The following is a description of a gene set: studied in species Mus musculus Cytokines mediate cell-cell communication in the immune system and represent important therapeutic targets. A myriad of studies have highlighted their central role in immune function, yet we lack a global view of the cellular responses of each immune cell type to each cytokine. To address this gap, the authors created the Immune Dictionary, a compendium of single-cell transcriptomic profiles of more than 17 immune cell types in response to each of 86 cytokines (>1,400 cytokine-cell type combinations) in mouse lymph nodes in vivo. A cytokine-centric view of the dictionary revealed that most cytokines induce highly cell-type-specific responses. For example, the inflammatory cytokine interleukin-1β induces distinct gene programmes in almost every cell type. A cell-type-centric view of the dictionary identified more than 66 cytokine-driven cellular polarization states across immune cell types, including previously uncharacterized states such as an interleukin-18-induced polyfunctional natural killer cell state. Mouse Gene Set: CUI_B_CELL_IL33_RESPONSE_UP Genes positively differentially expressed in cell type: B cell upon treatment with cytokine: IL-33 in mouse lymph nodes in vivo. from publication Cui A, Huang T, Li S, Ma A, Pérez JL, Sander C, Keskin DB, Wu CJ, Fraenkel E, Hacohen N (PMID 38057668), and this is the list of marker genes: Ifi209, Ly6a, Ifi213, Ifi27l2a, Slfn2, Stat1 (NCBI Gene Id 98183), Xaf1, Rnf213, Ifi47, Pml, Phf11b, Ifit3 (NCBI Gene Id 433243), Sp110, Pkib (protein kinase inhibitor beta, cAMP dependent, testis specific), Irf7, Rtp4, Parp14, Serpina3g, Ms4a4c, Trim30a, Bst2, Capg, Ifi203, Zbp1, Tor3a, Ifi35